The following is a description of a gene set: studied in species Mus musculus from publication Chen Y, Wang X (PMID 31504780) Genes predicted to be targets of miRBase v22 microRNA mmu_miR_325_3p in miRDB v6.0 with MirTarget v4 prediction scores > 80 (high confidence targets). Mouse Gene Set: MIR_325_3P, and this is the list of marker genes: Cdc42bpb, Tm6sf1, Tsc22d1, Krt76, Rnasel, Ncf4, Ikbip, Rnase2a, Ptprr, Rinl, Gpr3 (NCBI Gene Id 14748), Foxo4, Akap6, Pigg, Padi1, Lhx3, Ubb, Asprv1, Akr1c18, Mup14, Eif4a2, Rbl1, Slc25a16, AI593442, Gm15085, Usp47, Wwp2 (WW domain containing E3 ubiquitin protein ligase 2), Mtx3, Pbdc1, Ccdc117, Gspt1, Krtap22-2, Adra2b, Usp16, Cdkn1a, Chp1, Cox8a, Actr10, Tefm, Mup2, Dpy19l2, Ranbp6, Car10, Galnt13, Ctsh, Ntf3, Lrp3, Cxcr3, Map3k4, Siglecf, Pfkfb4, Pgk1, Rpf1, Klhl8, Mup7, Pik3r6, Krt81, Col11a1, Usp15, Wdr47, Wrn, Pamr1, Rabep2, H2az1, Gm20738, P2ry12, Syngr3, Epb41, Spinkl, Pilrb1, Gm527, Tprn, Fam120b, Luzp4, Aqp2 (aquaporin 2), Oc90, Slc17a6, Peg10, Hoxd13, Dmrt3, Skp1, Hnrnpr, Gramd2b, Pax9, Gpr25, Ifitm2, Virma, Get3 (guided entry of tail-anchored proteins factor 3, ATPase), Ehbp1, Ckmt2, Trappc3, Krt25, Gabra1, Igf2r, Caln1, Mlst8, Sp3 (trans-acting transcription factor 3), Rexo5 (RNA exonuclease 5), Sec23a, Slc39a8, Papss1 (3'-phosphoadenosine 5'-phosphosulfate synthase 1), Pacsin2, Klhl13, Adam12, Ppm1f, Ankrd34b (ankyrin repeat domain 34B), 2610528J11Rik, Hoxc4, Fabp9, Polr3d, Gli3, Kxd1, Cdc42se2, Rnaseh2b, Wnt6 (wingless-type MMTV integration site family, member 6), Katnip, Ubn2, Shroom4 (shroom family member 4), Bmi1, Cenpb, Adam23, Dab2, Clspn, Irf2bp1, Slc12a2, Gfm2, Cenatac, Nfyc, Fbxl20, Tbc1d4, Polm, Trpc3, Gpx5, Serpina9, Rasa1, Cyb561, Kcnk5, Loricrin, Adgrv1, Dpp4, Gng4, Gpr158, Eif2b3, Fam227b, Coq10a, Efemp1, Pdcd10, Cacybp, Ace2, Csn2, Tc2n, Dipk2a, Defb48 (NCBI Gene Id 432867), Slc36a1, Usp33, Rell2, Rps27l, Hgd, Krtap8-1, Cxcl13, Ppfia4, Zfp36l1, Gkn1, Cdk6, Slc38a2, Gsc, Zfp341, Pkp1, Tmem128, Fmod, Stx8, Serpinb5, Arl16, St8sia4, Nf1, Ssty2, Ugt1a6b, Hrnr, Dennd1a, Hnrnpl, Ugt1a1, Hexa, Srbd1, AI837181, Rpp25, Ptprm, Slc19a3, F2, Gabbr1, Nadk, Lrrtm4, Cfhr1, Dgat1, Inpp1, Celf2, Inava, Fut9, Slc10a3, Farsb, Dido1, Gapdh, Zfp423, Kcnj11, Prex2, Eeig2, Nav1, Cdk14, Gnao1, Magt1, Ces4a, Ltbp3, Nkx6-2, Rbm33, Gm6712, Nhsl1, Atg9b (autophagy related 9B), Sfxn3, Yeats2, Gm10375, Nus1 (NUS1 dehydrodolichyl diphosphate synthase subunit), Cma1 (NCBI Gene Id 17228), Esyt2, Erbb4, Ntsr2, Fam217a (family with sequence similarity 217, member A), Azin1, Foxk2, Sucla2, Adam25, Npc1, Cmpk1, Flcn, Samd14, Ampd3, She, Krt19, Etv6, Spink6, Fezf2, Ripk3, Calm1, Ctnnal1, Snai1, Krt84, Ccdc136, Slain2, Angpt1, Eri2 (NCBI Gene Id 71151), Aplp2, Proca1, Clca3a1, Mcl1, Sult1d1 (sulfotransferase family 1D, member 1), Ppp1r1c, Elavl1, Pdcd6, Ctbp2, Pax3, Atp11c, Gm20806, Ripk4, Unc93b1, Lamp2 (lysosomal-associated membrane protein 2), Map4k1, Mdc1, Prkacb, Rnf130, Kmt5b, Sh2d1a, Akt1, Epb41l1, Rnf146, Haao, Sec24d, Tssk6, Phlpp2, Vapb, Gja6, Adam24, Smim3, Cgnl1, Nynrin, Poldip3, Arhgef18, Lipa, Cercam, Ppm1d, Srsf6, Lrrc7, Dcun1d3, Steap2, Gm20816, Gpr137, Rasef, Wfdc2, Zfp963, Myl1, Prmt2, Fnip1, Foxp1, Rs1, Armcx1, Ctxn2, Cfap418, Cenpx, Supt4a (SPT4A, DSIF elongation factor subunit), Bex3, Psma7, Trpv4, Maip1, Npy6r, Bbc3, Elavl2, Slc1a2, Mlxipl, Esam, Mapkapk3, Ptk7, Plcb1, Phactr2, Ticam2, Lurap1l, Tril, Ppip5k1, Tsc22d3, Polb, Rslcan18, Panx2 (NCBI Gene Id 406218), Kctd4, Mup3, Serpinb1b, Zfp654, Trnt1, Ces2a, Exoc5, Serpinb8, Aebp1, Folr2, Radil, Unc119, Ct45a, Cftr, Fzd6, Hps1, Sdf2l1, Cul4b, Gtf2a2, Nfs1, Krtap10-31, Abcd2, Csn1s1, Dtx2, Zfp318, Usp48, Gabrg2, Ddx31, Mapk8ip2, Chrna9, Ptgdr, Tor1aip2, Zfp804a, Ugt1a5, Hars1, Myo18b (NCBI Gene Id 74376), Cdc37l1, Kcmf1, Ephx2, Tmem52b, Bpifb4, Zmynd12, Mup4, Ppip5k2, Sspn, Gabra6, Zranb3, Ky, Gxylt1, Psmc1 (protease (prosome, macropain) 26S subunit, ATPase 1), Whrn, Krtap2-20 (keratin associated protein 2-20), Tigd2, Cep57, Rbl2, Ces2c, Ccnb1, Icam5, Col12a1, Ppfia1, Clip3, Osgin2, Tusc2, Fdx2, Lrch2, Nrep, Rai1, Rbm27, Slc22a8, Impact, Gabarap, Adam22, Slc39a4, Fjx1, Pou2af1, Ap2b1, Plekhm3, Slitrk6, Papss2, Pcmtd2, Mypop, Trib2, Nars1, Mpc1, Sbds, Kcnk1, Nedd8, Art3, Phb2, Tead4 (TEA domain family member 4), Slc8a1, Egln3, Apobr, Mup19, Niban2, Eqtn, Mup11, Klk11, Il1rap, Armcx2, S100a10, Csrp1, Slc4a5, Faxc, Gm15107, Il1r1, Gsk3a, Hcar2, Gm15114, Anapc5, Cdca7l, Aadat, Cnot2, Lca5, Gpd2, Sema6b, Mup1, Dr1, Xpo7, Samd9l, Dnase1l1, Myoz1, Smg8, Lck (NCBI Gene Id 16818), Ipo5, Ppp4r2, Casz1, Mafk, Nrf1, Rem2, Acap2, Gm21943, Tmem201, Cdh9, Scpep1, Glra2, Cracd (NCBI Gene Id 75147), Stk11, Magee1, Acp5, Ryr3, Brinp3, Pnck, Satb2, Ngly1, Polr2c, Slc6a8, Gm20747, Arl8b, Smpdl3a, Pcx, Herc3, Srsf7, Sra1, Srr (NCBI Gene Id 27364), Vkorc1, Krt71, Arhgef6, Fkbp3, Supt5, Morn1, Sidt2, Kalrn, Tapt1, Psmg2, Ubr1 (NCBI Gene Id 99008), Oxsr1, Syce3, 0610030E20Rik, Mup20, Rag2, Laptm4a, 1700034J05Rik, B3galt2, Zfp385b, Maml1, Large1, Gon7, Tbccd1, Atp11b, Slc39a11, Gpr37, Pef1, Prr16, Stx12, Zscan22, Lrrc56, Prnd, Alg5, Col9a1 (collagen, type IX, alpha 1), Tmem199, Mmgt1, Mbnl1, Gtf2ird2, Acadm (acyl-Coenzyme A dehydrogenase, medium chain), Ptpn2, Spink11, Kcnip1, Plod3, Gm10377, Mrpl1, Map3k14, Dusp2, Emx2 (empty spiracles homeobox 2), Cox6c, Trak1, Ccm2l, Kbtbd3, Ranbp9, Ift43, Rasl11b, Igbp1b, Klf10, Ufc1, Nme2, Prps2, Rfx3, Kif20b, Ugt1a10, Negr1 (neuronal growth regulator 1), Tmpo, Ghr, Slc22a17, Arfgef2, Prrx1, Havcr1, Fga, Ddx5, Entrep3, Ncoa7, Clca3a2 (NCBI Gene Id 80797), Khdrbs1, Brox, Bcas3, Ugt1a2, Prkab1, Snn, Vim (NCBI Gene Id 22352), Hyou1, Lig1, Flvcr1, Epop (NCBI Gene Id 217147), Slfn1, Mup12, Arhgef17, Golim4, Ott, Evi2b (ecotropic viral integration site 2b), Ntsr1, Nlrc5, Tspan3, Usp28, Serpinb3a, Reps1, Nrsn2, Pi15, Lgals3, Syncrip, Rab30, Ncdn, Krtap6-2, Rab6b (NCBI Gene Id 77488), Coch, Ugt1a6a, Mef2c, Sertad2, Gjb3, Gm15097, Nicn1, Trim47, Wdfy1, H1f8, Prkar2b, Mdk, Diaph2, Rwdd2a, Pak1 (p21 (RAC1) activated kinase 1), Gm20823, Ehmt1, Plscr2, Zbtb18, Mepe, D630045J12Rik, Fbxo32, Impa2, Nid2, Spcs2, Tent5c, Rtl3, Gkap1, Acrv1, Jun, Ube2d3, Fos, Morf4l1, Ccn4, Psmc4 (NCBI Gene Id 23996), Slc16a10, Ube2g1, Ppp1r21, Slx4 (SLX4 structure-specific endonuclease subunit homolog (S. cerevisiae)), Fahd1, Map2, Chia1, Ak2, Msl2, Bora, Ahsa2, Pcnp, Tbx3, Hltf, Cabyr, Atp8b1, Klhl23, Mup8, Pcca, Psme1, Upf3b, Malrd1, Tmprss11d, Cpm, Crppa, Pspc1, Arhgef28, Ube2e2, Gdpd1, Pla2g15, Ccdc153, Sstr3, Lmcd1, Ugt1a9, Tppp3, Sgms1, Adarb1 (NCBI Gene Id 76716), Rasgef1a, Nbeal2 (neurobeachin-like 2), Rbm42, Gm20917, Tubb5, Spink8, Ugt2b1, Fabp3, Foxn4, Mup13, Esx1, Islr2, Inppl1, Cops8, Srf, Cmah, Sec24a, Armcx3, Alpk3, S100a4, Gm20867, Vwa5b2, Grem2, Mup17, Angptl3, Penk, Crisp2, Krt10, Ankhd1, Frmd5, Gprasp2, Fbxo9, Helt, Hirip3, Rassf7, Nudt6, Myo7b, Baz2b, Patj, Fpr1, Arhgef15, Igsf11, Krt13, Ift74, Dsp, Exph5, Ano3, Nup153, Abhd13, Slit2, Eme1, Atp1b4, Mdga2, Abhd8, Prodh, Llcfc1, G6pc2, Adam28, Tchh, Blzf1, 1700001F09Rik, Rptn, Slc1a1, Fem1al, Scn3b, Fmr1, Ptp4a3, Pnpt1, Hapln4, Plaat1, Il22ra2, Ppp3ca, Ppp1r27, Cldn1, Krtap11-1, Nkap (NFKB activating protein), Pax8, Nrip3, Siah2, Twf1, Pkm, Idh3b, Fbn2, Isoc1, Dmrt2, Dars1, Gbe1, Usp45, Ift27, Eda2r, Gpr155, Muc20, Svs5, Dennd2b, Cacnb3, Ifitm3, Kprp, Prrt4, Cdc25b, Shkbp1, Ank (NCBI Gene Id 52488), Cd248, Emc4, Gsdmd, Abcc5, Cldn34c1, D17H6S53E, Foxf2, Hipk1, Nup98, Il23a, Pdlim5, Cxadr, Palld, Pacs1, Oser1, Slc4a10, Cat, Prm1, Itpripl2, Prss22, Atp5f1b, Pdgfra, Aggf1, Fam241b, Bckdhb, Tmem81, Mbnl3, Prps1l1, Smurf1, Mup18, Capg, Mup5, Frmd6, Ankrd28, Creb5, Stag3, Cdkn1b, Fndc4, Amfr, Sfn, Lrif1, Stk25, Bmp7, Nckap5, Phf6, Samm50, Sh3bgrl, Kcnn3, Gucy1a2, Zfp940, Caprin2, Plekhh1, Vcf1, Col5a1, Ubtd1, Fthl17a, Ythdf3, Pdzrn4, Ccng1, Gm20809, Adgrb1, Otud7b, Tfap2b, Rhog, Gm20854, Agxt, Ubxn8, Krtap6-1, Rbms3, Hand2, 4921536K21Rik, Gprasp1, Enox1, Ociad2, Cabs1, Clu, Pigyl, Cadps, Ecel1, Dync1li2, B3gnt7, Lrrc19, Fdx1, Tpbg, Poli, Gnas (GNAS complex locus), Uck1, Wdr26, Mbd2, Phyhip, Ppm1a, Slc13a4, P3h3 (prolyl 3-hydroxylase 3), Atp5f1c, Afap1, Fam161a, Fbxo34, Cldn2, Tgs1, Gm20852, Herpud1, Adcyap1r1 (adenylate cyclase activating polypeptide 1 receptor 1), Rbm46, Hipk4, Gm15093, Sun1, Pcdh9, Arl6, Mup15, Septin2, Gm15091, Scgb1c1, Ccdc91, Itprid2, Runx2, Fzd8, Cpvl, Mylk4, Daw1, Cdca8, Mgat2, Sesn1, Naa15, Ap3m1, Zfp735, Chmp5, Chi3l1, Gabrb3, Matr3, Zfp36l3, Ccnt2, P2ry1, Mdga1, Pds5b, Efna4, Ddx6 (DEAD-box helicase 6), Tesk1, Krtap4-16, Lima1, Styk1, Epx, Esm1 (endothelial cell-specific molecule 1), Ccdc34, Arhgap1, Uba1, Postn, Ppargc1a, Ahctf1, Gramd1c (NCBI Gene Id 207798), Ppfia2, Lpl (NCBI Gene Id 16956), Galt, Tial1, Gsta3, Btbd8, Slc25a26, Akap11, Hpgd, Luzp2, Grm7, Rab35, Prxl2c, Mup10, Cdadc1, Mindy2, Syt1, Gm15127, Snai2, Hepacam, Nfil3, Afm, Prelid1, Sf1, Mapkbp1, Mup9, Pik3r1, Krtap19-5, Ap3b2, Acot8, Myf5, Cited2, Mup16, Pou3f4, Zcchc12 (zinc finger, CCHC domain containing 12), Dhx15, Ermn, Slc12a4, Ehmt2, Micall2, Efr3a, Cldn11, Edar, Mfsd11, Crkl, Tmed1, Oit3, Fbxw11, Lrit2, Adcy6, Commd10, Tspan12, Cldn3, Efl1, Miox, Ugt1a7c, Fbxo2, Gja1, Cd151, Pnma3, Lcorl, Cep83, Pdp1, Xiap, Nucb2, Msln, Mbtps1, Zdhhc24, Clec4g, Ifit1bl1, Wdpcp, Ybx3, Slc1a3, Tdrd3, Tg, Uqcrc2, Aloxe3, Inpp5a, C1qtnf12, Phf3, Apoa2, Ada, Apoa4, Serpinb3c, Pacrg, Abca2, Trex2, Snx25, Tbx22, Mpp1, Vsig1, Ncam1, Klhdc10, Dll4, Gm11992, Ccdc77, Pomc, Paxbp1, Zfp1009, Prickle2, Gm15080, Fcer1a, Stom, Ppcs